Given this list of marker genes PTDSS2, CANT1, BGN (biglycan), LRP6, GATM, EEF1B2, RAI2, PFKFB1, HAL, HTRA1, PIP4P2, IFT88 (NCBI Gene Id 8100), FDPS, LY6E, RPS3, MRPL9, ADARB1, SETD6, MCOLN2, CD1D, CYB5B, ARID3B, SLC25A53, DOCK7 (NCBI Gene Id 85440), HLA-DOA, CTSS, HSD17B4, PRNP, NXPH2, PRSS23, GSDME, PARP6, FGD3, ACIN1, SLC20A1, ZNF600, REEP6, GLRX, WNT5B, PNLIPRP1, HTR2C, MMP13, PCOLCE, PXN, H19, SLC1A2, STRA8, CYP2S1, CALU, SGIP1, CHAF1B, PRAP1, YES1, AHNAK, NOS2, SFRP2, PLAC8, ANKH, NCOA5 (NCBI Gene Id 57727), FBXW2, PLIN2, ST7, NCF4, TGDS, AARS1, PTPRS, KEAP1, FOSL1, COLGALT1, CUL1, KLF10, ALDH18A1, B4GALT6, TTF1, PTTG1, SUSD6, KRT1, SUPV3L1, RTTN, MAP3K1, EPN2, PHF13, MPO, STT3B, CENPA, NDRG1, KPNB1, ANG, CWC22, PERP, TRPC4, MTHFD2, POU1F1, OCA2, MYH4, EGR2, TBC1D24, PRKCE, GLI3, ENPP1, FRRS1, KMT2A, GNAI2, RPL39L, SHMT2, GLUD1, TMX1, MIOS, FKBP5, HLA-E, SGCD, CFTR, TIMP3, PTPRA, RNF6, RAB25, TXNIP, ANKFY1, PRPS1, RPS27, ISOC1, MEF2A, NMT2, SYT4, BRD4, DNAJB13, SARAF, STBD1 (starch binding domain 1), EPB42, RCAN3, TRAF4, ADIPOQ, FGA (fibrinogen alpha chain), HPGD, PLA2G12A, PPIE, ALPL, BCHE, HSD17B11, RAD51AP1, SASH1, STAB1, COL5A2, BCL2L11, HK2, NOCT (nocturnin), RPGR (NCBI Gene Id 6110), FXR1 (NCBI Gene Id 8087), NUP54, DARS1, UTS2R, DBF4, PAK2, DTX1, PRUNE1, SRXN1, BHMT, TAT, ZNF703, INVS, TWIST2, GHITM, TMEM150A, LUC7L3, MRAS, NEUROG2, IFT172, CPN1, STK39, CX3CL1, SESN1, GAS1, MAPK6, PRPH2, IRF1, ETF1, CISD1, CSF1R, UGDH, GRK6, NR2F1, APOC2, SPRTN (NCBI Gene Id 83932), GPM6B, LARP1, FAU, CYTIP, DDX17, TSC22D1, MYO5B, REG1B, TENM2, MGP, SRY, NFIB, NREP, CRMP1, FLNB, FZD4, CDCP1, here is a description of the gene set: Despite their enormous importance, the molecular circuits that control the differentiation of Th17 cells remain largely unknown. Recent studies have reconstructed regulatory networks in mammalian cells, but have focused on short-term responses and relied on perturbation approaches that cannot be applied to primary T cells. Here, we develop a systematic strategy – combining transcriptional profiling at high temporal resolution, novel computational algorithms, and innovative nanowire-based tools for performing gene perturbations in primary T cells – to derive and experimentally validate a temporal model of the dynamic regulatory network that controls Th17 differentiation. The network is arranged into two self-reinforcing and mutually antagonistic modules that either suppress or promote Th17 differentiation. The two modules contain 12 novel regulators with no previous implication in Th17 differentiation, which may be essential to maintain the appropriate balance of Th17 and other CD4+ T cell subsets. Overall, our study identifies and validates 39 regulatory factors that are embedded within a comprehensive temporal network and identifies novel drug targets and organizational principles for the differentiation of Th17 cells. Human Gene Set: GSE43955_1H_VS_20H_ACT_CD4_TCELL_DN from publication Yosef N, Shalek AK, Gaublomme JT, Jin H, Lee Y, Awasthi A, Wu C, Karwacz K, Xiao S, Jorgolli M, Gennert D, Satija R, Shakya A, Lu DY, Trombetta JJ, Pillai MR, Ratcliffe PJ, Coleman ML, Bix M, Tantin D, Park H, Kuchroo VK, Regev A (PMID 23467089) studied in species Homo sapiens Genes down-regulated in CD4 T helper cells Th0: 1h versus 20h.